The following is a description of a gene set: The presence of autoantibodies (immunoglobulins) in the serum that react against mitochondria. studied in species Homo sapiens Human Gene Set: HP_ANTIMITOCHONDRIAL_ANTIBODY_POSITIVITY Antimitochondrial antibody positivity, and this is the list of marker genes: LBR, TNPO3, MMEL1, IRF5, SPIB, LYN, IL12RB1, CD247, POU2AF1, TNFSF15, IL12A (NCBI Gene Id 3592)